The following is a description of a gene set: studied in species Homo sapiens from publication Ochiai K, Maienschein-Cline M, Simonetti G, Chen J, Rosenthal R, Brink R, Chong AS, Klein U, Dinner AR, Singh H, Sciammas R (PMID 23684984) Genes down-regulated in CD40L and IL-2 IL-4 IL-5 stimulated at day 1 B cell IRF4high versus CD40L and IL-2 IL-4 IL-5 stimulated at day 1 B cell wildtype. Temporal analysis of B cell activation in vitro using CD40L and IL-2/4/5 cytokines in wild type Irf4+/+ B cells or in mutant Irf4-/- B cells harboring a tet-inducible allele of Irf4. IRF4 expression was restored, or not, in the Irf4-/- background by culturing in the presence of low or high concentrations of doxycycline. The results provide insight in the role of IRF4 expression levels in coordinating different programs of B cell differentiation. Human Gene Set: GSE46606_IRF4HIGH_VS_WT_CD40L_IL2_IL5_DAY1_STIMULATED_BCELL_DN, and this is the list of marker genes: PRMT6, PAQR6, TRAF2, PTGIR, PRRT4, SAV1, MLLT6, CD38, RNPC3, EPS15L1, OR2C1, PCNP, CNIH4, KTN1, EBI3, MARVELD3, CTNND1, SMG8, IRF1, CXCR2, MUC13, MARCHF7, ARMC6, ZDHHC21, BUD31, REL, CRACD, PSMB7, TEX12, IL17RE, IL2RG, SOX18, MST1, KRT34, RAB20, CRY2, EML4, DNM1L, PSMD10, SDAD1, CLDND1, KRTAP17-1, GBP7, TREX1, CASP4, ADM, IRAK2, RIPK2, ZNFX1, PTPN9, BLZF1, MTM1, USO1, PPP3CC, NOP58, UBE2J2 (ubiquitin conjugating enzyme E2 J2), AGTRAP, WARS1, SHOC2, NRN1L, OVOL1, CDC27, GSAP, RNF31, AGBL4, SNORD123, RFFL, SEMA4C, ZC3H15 (NCBI Gene Id 55854), CYSRT1, SPHK1, PTGES, N4BP1, PMPCA, U2AF1 (NCBI Gene Id 7309), SEC24B, RALB, DHX15, STAU1, WHAMM, IL15, CLN5, PKMYT1, ZNF205, TMEM88, SMNDC1, PARP9, F3 (NCBI Gene Id 99486), KPNA3, INO80, FIP1L1, SLFN5, SPACA3, ECHDC3, PMM2, DNAJC5G, MAFF, TMEM200A, SPRED1, BFSP2, LENG1, AK5, ZHX1, RPS6KA2, KLF7, PIWIL2, FETUB, DNAJC21, SENP1, OPTN, PPP1R15B, TCP1, NFKBIZ, RAB32, PPP1R14C, PCDH10, LIAT1 (ligand of ATE1), CYRIA, CCIN, MAPK8, TRA2A, FILIP1L, ZC3H12A, SHD, SLC7A2, CCDC65, HSP90AA1, CASR, PDE12, CLIC4, GRAMD1A, CIAPIN1, C3, SEMA3F, PCDH9, CERS6, EFNA2, FLT3, UBTD2, ALCAM, VCAM1, TRIP10, HSPA13, VDAC3, PPM1B, ICOSLG, DNAJC22, DCAF13, FGF1, KCTD12, RSPRY1, LRFN2, PIK3R6, PSME2, INTS12, SUSD6, CPSF2, ATP6V1E1, ADORA2B, CACNG7, HMGCS2, SLC22A16, ZFAND5, EIF6, LRRC59, FBXL3 (F-box and leucine rich repeat protein 3), LANCL2, SLC8A2, SMARCE1, CD47, HRG, BCLAF3, TUT1, RAP2C, PNP, HEATR6, AGFG1, SPAG8, SLC30A6, CFAP43, TXLNB (NCBI Gene Id 353506), CDV3, AFF1, FRMPD1, GLS, LACC1, DAAM1, TANK, SFTPD, TFAP2B, CTSC, KDM4B, STIP1, MAPK1IP1L, SAP30, RBM12, DGKH, GALR1, MYBPH, COL4A6